Given this list of marker genes USP20, OTUB2, USP17L2, BAP1, OTUD7B, MINDY3, USP8, OTUD4, YOD1, OTUB1, MINDY4, USP33, USP34, USP27X, UBXN1, USP29, VCPIP1, MINDY4B, PARK7, USP25, USP5, USP14, OTUD5, USP37, TNFAIP3, ATXN3, OTUD3, here is a description of the gene set: studied in species Homo sapiens Human Gene Set: GOBP_PROTEIN_K48_LINKED_DEUBIQUITINATION A protein deubiquitination process in which a K48-linked ubiquitin chain, i.e. a polymer of ubiquitin formed by linkages between lysine residues at position 48 of the ubiquitin monomers, is removed from a protein.